The following is a description of a gene set: TLR1 is expressed by monocytes. TLR1 and TLR2 cotranslationally form heterodimeric complexes on the cell surface and in the cytosol. The TLR2:TLR1 complex recognizes Neisserial PorB and Mycobacterial triacylated lipoproteins and peptides, amongst others, triggering up-regulation of nuclear factor-kappaB production and apoptotic cascades. Such cooperation between TLR1 and TLR2 on the cell surface of normal human peripheral blood mononuclear cells, for instance, leads to the activation of pro-inflammatory cytokine secretion. Reactome Pathway: Toll Like Receptor TLR1:TLR2 Cascade part of: Toll Like Receptor 2 (TLR2) Cascade species: Homo sapiens, and this is the list of marker genes: SFTPD, CUL1, S100A1, MAP2K1, PELI3, S100A12 (NCBI Gene Id 6283), RPS6KA1, NOD2, APP (NCBI Gene Id 351), MAPK8, PPP2CB, TP53 (tumor protein p53), SIGIRR, NKIRAS1, TRAF2, NFKBIB, DUSP3, TRAF6, S100A9, NOD1, MAPK14 (NCBI Gene Id 1432), N4BP1, S100A8, MAP3K1, SKP1, MYD88 (NCBI Gene Id 4615), N, CASP8, VRK3, JUN, TLR2, IRAK4, FOS, PELI2, FGB, UBB, MAP2K6, ALPK1, NFKB2, NFKBIA, IRAK1, MAPK3, RELA (RELA proto-oncogene, NF-kB subunit), NLRX1, IKBKG, NLRC5, RPS6KA3, USP18, MAP2K3, AGER, MEF2C (NCBI Gene Id 4208), S100B, MAPKAPK3, IRAK3, FGA, TAB3, MEF2A, MAPK1, mip, DUSP6, PPP2CA, CD36, DUSP7, SFTPA1, USP14, PELI1, NKIRAS2, MAP3K7, UBA52, TLR6, SOCS1, UBE2V1, RPS27A, UBE2N, TIFA, MAP2K4, TLR1, TNIP2, MAPK7, CHUK, MAPK10, LY96, DUSP4, NFKB1 (nuclear factor kappa B subunit 1), PPP2R1A, TAB1, RIPK2 (NCBI Gene Id 8767), HMGB1, PPP2R1B, IKBIP, BTRC, CREB1, ATF2, SAA1, porB, ELK1, PPP2R5D, CD14, IRAK2, FGG, LRRC14, UBC, MAPKAPK2, MAPK9, TIRAP, MAP3K8, RPS6KA5, ECSIT, MAPK11, TLR4, IKBKB, ATF1, MAP2K7, SFTPA2, BTK, TAB2, FBXW11, RPS6KA2